The following is a description of a gene set: studied in species Homo sapiens STAT3, an essential transcription factor with pleiotropic functions, plays critical roles in the pathogenesis of autoimmunity. Despite recent data linking STAT3 with inflammatory bowel disease, exactly how it contributes to chronic intestinal inflammation is not known. Using a T cell transfer model of colitis we found that STAT3 expression in T cells was essential for the induction of both colitis and systemic inflammation. STAT3 was critical in modulating the balance of T helper 17 (Th17) and regulatory T (Treg) cells, as well as in promoting CD4+ T cell proliferation. We used chromatin immunoprecipitation and massive parallel sequencing (ChIP-Seq) to define the genome-wide targets of STAT3 in CD4+ T cells. We found that STAT3 bound to multiple genes involved in Th17 cell differentiation, cell activation, proliferation and survival, regulating both expression and epigenetic modifications. Thus, STAT3 orchestrates multiple critical aspects of T cell function in inflammation and homeostasis. from publication Durant L, Watford WT, Ramos HL, Laurence A, Vahedi G, Wei L, Takahashi H, Sun HW, Kanno Y, Powrie F, O'Shea JJ (PMID 20493732) Human Gene Set: GSE21670_UNTREATED_VS_TGFB_TREATED_STAT3_KO_CD4_TCELL_UP Genes up-regulated in CD4 T cells with STAT3 knockout: medium versus TGF beta., and this is the list of marker genes: QPRT, DDX19A, PATJ, FXR2, TRAPPC9, FABP6, CEP85 (centrosomal protein 85), SLC1A4, SUOX, WASF3, NR1D1, MEP1A, ZNF786, MIX23, TCTE1, CARD14, ARF5, EGR1, KDM4A, FXYD4, SOCS7, CD79A, RFX2, PEX10, F2R, SRCIN1, CCDC97, TMCC1, CCL25, TMEM44, NLRP9, WIPF2, IL17B, TGIF2, HDHD3, FAM162B, WNT8A, AP1G2, SERPINB6 (NCBI Gene Id 5269), HYAL4, GABRA5, RUSC2, CCDC146, ARMC9, LTBP1, RBM4B (NCBI Gene Id 83759), PLCH2 (phospholipase C eta 2), NRCAM, GJA4, NSUN4, SMARCD3, RAC3, CPSF4L, NSD3, CCDC65, L1TD1, SELENOW, HDAC3, SNX15, HDAC10, DZIP3, PLXNB3, SUZ12, PATZ1, KCND3 (potassium voltage-gated channel subfamily D member 3), SMC5, ARHGAP6, MMP9, P3H2, PLEKHO2, PIK3C2G, PRAP1, SHISA3, LGALS4, PIGV, IRF7, LBX2, ASAP2, RGS12, PERP, ARMC3, ECHDC2, DUS4L, GON4L, S1PR4 (sphingosine-1-phosphate receptor 4), SIX5, PBX1, ST8SIA5, ZBTB45, REG4, DACT2, GDNF, ZP3, BHLHE23, C2CD2, MINK1, PLPP3, CHEK2 (checkpoint kinase 2), DPF3, EFCAB14, UBL7, RPS18, ELMOD1, CAVIN3, DHRSX, C12orf43, XKR5, ATP1A2, CHIA, NRIP3, BRINP1, STS, RICTOR, FOXO1, TSC22D1, DDR1, RBMS2, MYO18B, TACR1, KIF1C, NCAPG, VAMP8, IL21, MPP7, SPATA2, LRSAM1, PLEKHG5, EFCAB6, TNPO2, TGFB1I1, KSR1, PGPEP1, TSPAN13, SNAPC5, AMER1, CIB2, ZMAT2, NCAN, YJEFN3, DTX3, CARF, ZNF446, HYAL2, HSPA1L, CTTN, NUAK1, ADCYAP1R1, FAM184A (family with sequence similarity 184 member A), GNS, DSC3, MLST8, NCAM2, NLGN1, TSC1, NEK5, FHIP1A, PRR13, GNPDA1, IFT140, MOB3C, AAMDC, ADCY9, SERTAD1, MACROD1, CYLC2, ESRRG, CILK1, RAB30, ALB, PGGHG, HLA-B, GSTA3, RPL23, PCMT1, NIPAL3, TMEM80, PCDHGC4, PPIF, OTOP1, TPCN1 (two pore segment channel 1), SLC39A4, NEK8, TCTN2, RAB42, TMEM222, SYT6, SPIRE2, UBL5, DEXI, FBXO36, CAPN9, IDO1, RHOD, THOC2, RPS23, MIDEAS, NKX2-1, CLN6 (NCBI Gene Id 54982), ELAPOR1